Given this list of marker genes Parp10, Pold3, Polk, Rev3l, Primpol, Vcp (valosin containing protein), Pole2, Polq, Rev1, Sprtn, Pold1, Pclaf, Poli, Zbtb1, Pcna, Mad2l2, Dtl, Poln, Pold2, Faap20, Polh, Poldip2, here is a description of the gene set: The replication of damaged DNA by synthesis across a lesion in the template strand; a specialized DNA polymerase or replication complex inserts a defined nucleotide across from the lesion which allows DNA synthesis to continue beyond the lesion. This process can be mutagenic depending on the damaged nucleotide and the inserted nucleotide. species: Mus musculus Mouse Gene Set: GOBP_TRANSLESION_SYNTHESIS